Given this list of marker genes Hdac3, Hdac7 (NCBI Gene Id 56233), Hdac2, Hdac1, Hdac6, Hdac9, Hdac5, Hdac11, Hdac8, Hdac4, Sirt1, here is a description of the gene set: studied in species Mus musculus Catalysis of the reaction: H2O + N6-acetyl-L-lysyl- = acetate + L-lysyl-. Mouse Gene Set: GOMF_HISTONE_DEACETYLASE_ACTIVITY_HYDROLYTIC_MECHANISM